Given this list of marker genes RAB13, RAE1, BTBD3, C2CD4A, WDR75, SERGEF, IFFO2, H2BC8, SUMO2, ANP32B, MAP3K4, GLMN, TPX2, CDCA3, TUG1, ZNF300, NEMP1, TDRD9, KIF18A, ZBED5, EZH2, LMNB1, CEP135, FANCI, SLC35D3, TAF5, MRE11, DNM1L, ZNF605, CYTH2, SANBR (SANT and BTB domain regulator of CSR), MELK, RAB34, HK2, TDG, RIC8B, EPC1, NUAK1, GOLGA3, GPD2, MACROH2A2, STIL, DNA2, STK4, TOP2A, OLA1 (NCBI Gene Id 89690), HYCC1, ARID3A, CKAP2L, RAD54L, DCLRE1C, KIF20B, KIAA1958 (NCBI Gene Id 377812), S100A14, H4C3, MARCHF3, IFT57, DLGAP5, ECT2, CDC25A, PCYOX1L, DEPDC1B, ALMS1, ZNF397, ZWINT, SOX9, INTS4, CASP2, MKI67, KIF23 (kinesin family member 23), NCAPH, EMC3-AS1, KIF4A, GINS1, PTTG1, CENPM (centromere protein M), ZNF354A, AP1G2, ZNF263, MAPK13, ZNF292, P3H4 (NCBI Gene Id 10609), PDZD8, DENND2B, FZD10, BLM, BARD1, CEP290, NCAPG, GPSM2, STMN1, DROSHA, RRP1B, PIGA, GAL3ST1, GPR157 (G protein-coupled receptor 157), RRM1, STRBP, THOC1, DDX4, SFI1, SIPA1L3, C2CD5, DHRS13, KLHL42, MEX3C, KNTC1, CENPE, COL22A1, SOX4, MCM6, CDCA8, CDS1, RBPJ, CDC7, CA5BP1, NLRP4, HMGXB4, POLD3, CENPO, PCLAF, USP37, ADAM17, KIF20A, FMO9P (flavin containing dimethylaniline monoxygenase 9, pseudogene), AGO1, BUB1, NDE1, RFX3, TRMT6, HJURP, NDC80, ANLN, ARX, METTL9, CCDC28B, DEFA5, USP4, METTL8, GABRB3, SGO2, NAP1L1, PHTF2, POLA1, CDC20, PTPRA, POGLUT2, KIF2C, TAC1, CTNND2, CWC22, USP28, JPH3, UPF3B, DDX27, MCM8, SFMBT1, ZNF678, ZNF532 (NCBI Gene Id 55205), PNMA3, TTK, CEP55, NR6A1, CDC25B, TENT5C, KIF15, GNPTAB, MCM10, NCOA6, PLK4, FUBP1, SALL4, TROAP, DCLRE1B, ARID2, here is a description of the gene set: Genes over-expressed in KRT19-positive hepatocellular carcinoma (HCC). In approximately 70% of patients with hepatocellular carcinoma (HCC) treated by resection or ablation, disease recurs within 5 years. Although gene expression signatures have been associated with outcome, there is no method to predict recurrence based on combined clinical, pathology, and genomic data (from tumor and cirrhotic tissue). We evaluated gene expression signatures associated with outcome in a large cohort of patients with early stage (Barcelona-Clinic Liver Cancer 0/A), single-nodule HCC and heterogeneity of signatures within tumor tissues. species: Homo sapiens from publication Villanueva A, Hoshida Y, Battiston C, Tovar V, Sia D, Alsinet C, Cornella H, Liberzon A, Kobayashi M, Kumada H, Thung SN, Bruix J, Newell P, April C, Fan JB, Roayaie S, Mazzaferro V, Schwartz ME, Llovet JM (PMID 21320499) Human Gene Set: VILLANUEVA_LIVER_CANCER_KRT19_UP